The following is a description of a gene set: Up-regulated genes in MM1.S cells (multiple myeloma) treated with adaphostin, a tyrosine kinase inhibitor with anticancer properties. Here we show the antimyeloma cytotoxicity of adaphostin and carried out expression profiling of adaphostin-treated multiple myeloma (MM) cells to identify its molecular targets. Surprisingly, c-Jun was the most up-regulated gene even at the earliest point of analysis (2 h). We also observed adaphostin-induced c-Abl cleavage in immunoblot analysis. Proteasome inhibitor bortezomib, but not melphalan or dexamethasone, induced similar effects, indicating unique agent-dependent mechanisms. Using caspase inhibitors, as well as caspase-resistant mutants of c-Abl (TM-c-Abl and D565A-Abl), we then showed that c-Abl cleavage in MM cells requires caspase activity. Importantly, both overexpression of the c-Abl fragment or c-Jun and knockdown of c-Abl and c-Jun expression by small interfering RNA confirmed that adaphostin-induced c-Jun up-regulation triggers downstream caspase-mediated c-Abl cleavage, inhibition of MM cell growth, and induction of apoptosis. Finally, our data suggest that this mechanism may not only be restricted to MM but may also be important in a broad range of malignancies including erythroleukemia and solid tumors. Human Gene Set: PODAR_RESPONSE_TO_ADAPHOSTIN_UP from publication Podar K, Raab MS, Tonon G, Sattler M, Barilà D, Zhang J, Tai YT, Yasui H, Raje N, DePinho RA, Hideshima T, Chauhan D, Anderson KC (PMID 17308109) studied in species Homo sapiens, and this is the list of marker genes: CYTIP, NFE2L1, DUSP1, GLA, NAP1L1, CLK1, VEGFA, BACH1, DNAAF1, MARS1, CSGALNACT2, CLU, NEAT1, FNDC3A, GCLM, CCNG2, ARID5B, STEAP1, MORC3, SLC38A2, ZFP36L1, MSX1, IFNGR1 (NCBI Gene Id 3459), GAB2, ACTR10, CEBPG, DNAJB1, IGFBP3, IFRD1, IL23A, YPEL5, CREM, ATF3, GABARAPL1, MAFG, OSER1, MBNL2, TMCO3, NEK1, ZFAND5, TNFSF9, CLEC2B, NCF2, TES, PMAIP1, CHAC1, HAPSTR1, KLF2, RPL13P5, RPS6KC1, STX12 (syntaxin 12), HSPA1B, TMEM140, PLEK, PALLD, RGS2, CEBPB (NCBI Gene Id 90277), ITGAX, MXI1, RAB9A, JUND, GLRX, CD44 (NCBI Gene Id 960), CCSER2, RND3, TRIB3, HSPA1A, SLC3A2, MFAP4, PIR, GTPBP2, FTH1, AKR1C3, WDR26, CDKN1C, KLF6, RAP2B, PRDM4 (PR/SET domain 4), SLC7A11, ASF1A, ZNF215, MAFF, DNAJB4 (NCBI Gene Id 11080), EIF2AK3, PNRC1, GARS1, ZNF267, JUN, MACO1, NLRP1, DGKG, ISG20, DDIT4, CD55, GADD45A, HMOX1, TUBA1A, P4HA2, ZEB1, HEXIM1, HDLBP, FNDC11, MGAT2, FYN, DNAJB9, TRIB1, NCOA2, IL15 (NCBI Gene Id 3600), SQSTM1, SOX4, H2BC3, ASNS (NCBI Gene Id 440), CCPG1, SEC24D, ZNF165, DNAJB2, ATF4, BBC3, HSPA13, BSDC1, GOLGA2, MIR22HG, KLHL21, HSPA6 (NCBI Gene Id 3310), DDIT3, PSAT1, SAT1, STX3, ANXA1, HSPB1, HBP1, AKR1C1, ID2, ZBTB43, TUBB2A, H2AC18, ARMCX3, NAP1L2, CARS1 (NCBI Gene Id 833), CLIC2, MAP1LC3B, DUSP5, ADAM17, FTH1P5, NIBAN1, RB1CC1, PPP1R15A, IER5